Given this list of marker genes SLC66A3, PPP2R5A, PIP4K2C, BNIP3 (BCL2 interacting protein 3), CRYL1, GPRASP1, BTN3A1, ARL6IP5, GSN-AS1, TPK1, ARHGEF3, EPS8L2, FBXO3, VOPP1, RPL21, ROR2, LY9, APOL3, NEK3, GP5, ALDH3A2, CAMSAP2, RHOF, MEGF6, GOLGA8A, RASSF2, PRKACB, ZBTB20, ZNF14, TNF, TNIP2, FGF9, NLRP1, NCOA2, TET3, LDOC1, CCDC134, PRMT2, STX16, ULK2 (NCBI Gene Id 9706), GPR183, ATP2A1, ERGIC2, SNRK, CD53, P3H4, SERP1, KCTD7, MARF1, DUSP13B, GVINP1, CLEC2B, HLA-G, SIRPG, SLC35D2, PLEKHA1, MMP19, ITIH1, PDXK, IFITM1, APBB1, SQSTM1, ADORA2B, ITPKB, RGCC, CIB1, CACNA2D2, PPARD, SLC15A3, DNAAF8, AK5, BIN2 (bridging integrator 2), FADS3, CLK4, IL4R, PVT1, KREMEN2, RRAS, OSTM1, PLA2G10, CHRNA2, IL27RA, IGBP1, TMEM9B, FLT3LG, CBFA2T2, KDM7A, HABP4, ZNF224 (NCBI Gene Id 7767), LPIN2, CAPRIN2, EVI2B, JAK1, FNBP4, PDE4B, MYLIP, SLAMF1, IER2, LRRN3, RETREG1, CDC42SE1, KRTAP5-8, MPHOSPH8, P2RY2, VIPR1, CTSF, KAT2B, APH1B, PASK, GALNT11, NFKB1, ATG14, ITFG2, CKAP4, ACTN1, GARRE1, TOR1AIP1, CRLF3 (cytokine receptor like factor 3), FXYD5, LINC00623, CYTIP, SKAP1 (NCBI Gene Id 8631), CDC14B, SYNE1, PDE4DIP, RCAN3, CD55, S100A6, ALPG, DRICH1, DENND2D, TMBIM1, CDR2, CSF3, MT1F, LOX, PHF1, GRB10, ARHGEF10, MAPK13, ZFP36L1, AKTIP, LCP2, NDRG1, COL6A1, PLEK2, SPOCK2, CCDC88C, EVI2A, FTL, RIN3, SMIM27 (NCBI Gene Id 548324), AP3M2, RPL10P17, ZNF37BP, PCDHGA9, GSG1, TMEM204, LIN7B, CITED2, IKBKE, FNDC3B, RPL3L, SLC9A8, TGOLN2, TIMP1, KLF3, NEBL, EEF1G, KRT2, DGCR2, PLCL2, FUCA1, CYLD (CYLD lysine 63 deubiquitinase), SH2D3A, ZMYM6, HLA-J, MSN, PLP2, KCNH2, TKTL1, ASNS (asparagine synthetase (glutamine-hydrolyzing)), CD247, NAP1L2, APLP1, FAM171A1, ECHDC2, ZNF331, KLF7, PEX19, KCNAB2, RAB29, MYOM1, NGFR, IRF9, GBX2, here is a description of the gene set: from publication Lee MS, Hanspers K, Barker CS, Korn AP, McCune JM (PMID 15210650) Subpopulations of human fetal thymocyte and circulating naïve T cells were obtained through FACS sorting, including CD3-CD4+CD8- intrathymic T progenitor cells (ITTP), CD3intCD4+CD8+ \double positive\ thymocytes (DP), CD3highCD4+CD8- \single positive\ thymocytes (SP4), CD3+CD4+CD8-CD45RA+CD62L+ naive T cells from cord blood (CB4+), and CD3+CD4+CD8-CD45RA+CD62L+ naive T cells from adult blood (AB4+). Genes down-regulated in comparison of intrathymic T progenitor cells (ITTP) versus naive CD4 T cells from adult blood. species: Homo sapiens Human Gene Set: GSE1460_INTRATHYMIC_T_PROGENITOR_VS_NAIVE_CD4_TCELL_ADULT_BLOOD_DN